The following is a description of a gene set: species: Mus musculus Mouse Gene Set: GOBP_RESPONSE_TO_MUSCLE_INACTIVITY Any process that results in a change in state or activity of a cell or an organism (in terms of movement, secretion, enzyme production, gene expression, etc.) as a result of a muscle inactivity stimulus., and this is the list of marker genes: Pik3ca, Actn3, Scn5a, Fbxo32, Sgca, Dag1, Mtmr4, Casq1, Trim63, Dmd, Myog, Hdac4